Given this list of marker genes DNAJC19, IRGQ, ZNF577, C15orf48, PEA15, MYB, FAM3C, TET3, MDGA1, PRKCA, PRSS35, SGPP1, TTLL12, ZFP91, GABRA3, RAB12, ZNF514, GATAD1, C1orf21, NDC1, SPOCK1, SMDT1, SMNDC1, NTRK2, SZRD1, SYNGR1, MAGOHB, PPFIA2, NWD1, CHEK1, PAPPA, IGF2BP1, ZNF732, TMEM132C, CORO1C, EREG, MTCH2, FBXO32, INPP5A, PEX7, ZNF267, GRIK3, ATP4B, TP53INP2, SPC24, ADPRH, SH3TC2, POU2F1, CLSPN, MBD6, C22orf46P, CELSR1, ELOVL3, ZFX, SETD7, KRBOX4, VTI1A (vesicle transport through interaction with t-SNAREs 1A), FAM76A, DACT3, SCD5, PAX5, ZDHHC11, TNRC6B, MTHFD2, DNAJC22, GALNT1 (NCBI Gene Id 2589), ZNF182, SPINT2 (NCBI Gene Id 10653), SPOPL, CDSN, GRHL2, KIF11, PROP1, here is a description of the gene set: Human Gene Set: MIR2116_3P species: Homo sapiens from publication Chen Y, Wang X (PMID 31504780) Genes predicted to be targets of miRBase v22 microRNA hsa-miR-2116-3p in miRDB v6.0 with MirTarget v4 prediction scores > 80 (high confidence targets).